Given this list of marker genes Ephx2, Ephx1, Ephx3 (NCBI Gene Id 71932), Alox12, Alox5, here is a description of the gene set: studied in species Mus musculus Mouse Gene Set: GOBP_EPOXIDE_METABOLIC_PROCESS The chemical reactions and pathways involving epoxides, compounds in which an oxygen atom is directly attached to two adjacent or non-adjacent carbon atoms of a carbon chain or ring system; thus cyclic ethers.